The following is a description of a gene set: Mouse Gene Set: GOMF_R_SMAD_BINDING Binding to a receptor-regulated SMAD signaling protein. species: Mus musculus, and this is the list of marker genes: Smurf1, Pparg, Rgcc, Arap1, Fos, Drosha, Foxh1 (forkhead box H1), Trim33, Ppm1a, Smad6, Myocd, Smad3, Pmepa1, Zeb2, Zc3h3, Parp1, Jun, Stub1, Pax6, Ranbp3, Ddx5, Smad2, Ldlrad4, Men1, Ankrd1, Axin1, Smad4